The following is a description of a gene set: Human Gene Set: GOBP_ALCOHOL_CATABOLIC_PROCESS species: Homo sapiens The chemical reactions and pathways resulting in the breakdown of alcohols, any of a class of compounds containing one or more hydroxyl groups attached to a saturated carbon atom., and this is the list of marker genes: ALDH3B2, SULT1A2, CYP27A1, AKR1C3, CYP39A1, ACSS1, SNX17, ALDH1B1, GK5, ALDH3B1, ALDH2, AKR1D1, SCARF1, APOE, GPD2, AKR1B10, ACSS2, SULT1C4, GK2, TPI1, NUDT3, ADH4, CYP7A1, SULT1B1 (sulfotransferase family 1B member 1), TKFC, SULT1A1, NTSR1, SULT1A4, MIOX, SCARB1, HAO1, SULT1E1, GK, CYP46A1, SULT1A3, SRD5A3, SORD, SULT2A1